The following is a description of a gene set: studied in species Homo sapiens from publication Chen Y, Wang X (PMID 31504780) Genes predicted to be targets of miRBase v22 microRNA hsa-miR-6747-5p in miRDB v6.0 with MirTarget v4 prediction scores > 80 (high confidence targets). Human Gene Set: MIR6747_5P, and this is the list of marker genes: AAK1, PKD1L2, PILRB, FOXI1, PARS2, CCL21, FCER2, SYNGAP1, CALML4, PPP1R3G, MCCD1, SLC25A23, FZD8, EFNA5, MET, RAD51B, TMEM176A, MDGA2, ZDHHC3, CD302 (NCBI Gene Id 9936), NFKB2, SRGN (NCBI Gene Id 5552), MAX, SLC48A1, SLC13A5, NCDN, ZKSCAN5, KIF21B, GIGYF2, KCNC4, TBC1D20, IGFBP5, SOX12, CDC6, LY75-CD302, IL34, CSAG3, BEST1, PPP3CB, VAMP2, TBC1D19